Given this list of marker genes PLA2G3, PLA2G4B, PLA2G2E, LPCAT1, PLA2R1, PLA2G2A, LPCAT4, PLA2G10, CRLS1, PLA2G4D, PLA2G4F, PLA2G1B, PLA2G12A, PLA2G2F, PLA2G2D, PLA2G4A, PLA2G5, LPGAT1, here is a description of the gene set: In the acyl chain remodelling pathway (Lands cycle), phosphatidylglycerol (PG) is hydrolyzed by phopholipases and subsequently reacylated by acyltransferases. These cycles modify the fatty acid composition of glycerophospholipids to generate diverse molecules asymmetrically distributed in the cell membrane. The events occur additionally in the inner mitochondria membranes (IM) as well as in the endoplasmic reticulum (ER) membrane. Reactome Pathway: Acyl chain remodelling of PG part of: Glycerophospholipid biosynthesis studied in species Homo sapiens